Given this list of marker genes ZBTB44, LRFN2, DLGAP4, FBXL19, ZXDB, TRPC4AP, NAV2, NFXL1, WDTC1, MAPK8IP1, MAFG, KLHL3, MAGI1, KLHL1, HAP1, TMEM9, CDX2, GABBR2, COL11A2, REEP1, OTUD5, MCHR1, SCML2, PDGFRA, FURIN, CLCN6, PTPRD, TRIM33, APOA5, INPP5B (NCBI Gene Id 3633), MEN1, PIM2, PHF23, MMP14, BCL2L11, RAB5B, DOCK3, PLPPR2, SEMA4A, RAP1A (RAP1A, member of RAS oncogene family), VSTM4, TAF5, RANBP10, ARPP21, STRADB, DYRK2 (dual specificity tyrosine phosphorylation regulated kinase 2), MBOAT7, B3GNT6, SFXN5, ADPRM, ADCY9, CACNB1, ATP6V0A2, CNOT6, PHC1, FAM78B, HIP1R, CDV3, CMTM4, IP6K2, HIC2, RNF2, ING5, RAP2C, MATR3, C8orf58, ACBD4 (acyl-CoA binding domain containing 4), EPHA8, LMBR1L, SYP, CNTFR, ATP13A2, DCAF11, PER2, DDN, BHLHE22, ADAM19, VAV1, SMCR8, ACVR1B, YBX2, IGFBP5, NEK9, PYY2, LYPLA2, PIP5K1B, CITED4, MARCKSL1, CCT3, EXOC5, AARS1, SP1, YOD1, RNF150, MBD6, H2AX, AMOTL2, FST, NAPRT, MXI1, PLK3 (NCBI Gene Id 1263), C17orf49, RASA1, VXN, NDST1, PLOD2, BSN, ABCB9 (ATP binding cassette subfamily B member 9), MLEC, RAB5C, GPC4, MIDN, INSIG1 (insulin induced gene 1), TMCC2, RHBDL1, KDM5C, TRIM55, TRPM6, PTPRF, AJUBA, ANGEL1, SLC26A10P, SAP130, PIM1, GPAT3 (glycerol-3-phosphate acyltransferase 3), PRKRIP1, MIX23, CLK2, DAGLA, APBA1, DNAJB12, MAPK7, NEUROD1, RNF11, TOB2, NELL2, TMEM161B, NEDD9, SMAGP, MOCS1, ZXDA, HNF1B, PURA, KPNA3, BCL2L2, CCDC88B, SCRT2, PSAP, ARK2C, OGT (O-linked N-acetylglucosamine (GlcNAc) transferase), PRSS8, SLC12A6, XPO4, PTGER4, RNF138, SBK1, S1PR1, SEMA6B, PTPN9, RASGRP4, SLC19A2, PIGS (NCBI Gene Id 94005), SP6 (NCBI Gene Id 80320), PCNX2, ZER1, CENPT, GBA2, TNFRSF19 (TNF receptor superfamily member 19), PCDH17, DLC1, DUSP16, RAP1B, ARID5B, STC2, GRIA3 (glutamate ionotropic receptor AMPA type subunit 3), KMT5C, NEK4, AMMECR1, ZNF217, TOP1, PCDH10, GPX3, CD164L2, PPM1G, TSPAN14, KCTD21, FGFR3, PAK4, PARP6, SRGAP3, MNT, POGZ, VGLL3, G6PD, DHX30, DCBLD2, NSD2, C14orf180, CSK, CLIP2, KIF21B, CALCR, PSKH1, DENND5A, GAL3ST3, RARG, TAOK1, KCNK2, NEFM, CLUH, EDA, CREBL2, ARHGEF5, PER1, SSH2, MMP16, RGL2, TAB2, RASSF2, AVL9, SZT2, MARK4, SNN, PHF20L1, STX5, PLCL2, REXO1L1P, SESN1, MTMR14, CDKN1B, ACAN, here is a description of the gene set: studied in species Homo sapiens Genes having at least one occurence of the motif CTGAGCC in their 3' untranslated region. The motif represents putative target (that is, seed match) of human mature miRNA hsa-miR-24 (v7.1 miRBase). Human Gene Set: CTGAGCC_MIR24